The following is a description of a gene set: The autophagy process which begins when chaperones and co-chaperones recognize a target motif and unfold the substrate protein. The proteins are then transported to the lysosome where they are degraded. Mouse Gene Set: GOBP_CHAPERONE_MEDIATED_AUTOPHAGY studied in species Mus musculus, and this is the list of marker genes: Snca, Hspa8, Lamp2, Clu, Atg5, Synpo2, Gfap, Plk3, Ctsa (cathepsin A), Atg7 (autophagy related 7)